Given this list of marker genes PCNA, ABCC3, RAP1A, ATF6, FRAT2, XPC, BTK, RHOT2, CXCR4, ERBIN, SRF, TMEM147, OSBP, SMARCD2, UQCRHL, GUSB (glucuronidase beta), ATP5MC3, KCNE5, TESK2, MGST2, SLC25A45, TIA1, TRIM11, HCFC1, C6orf136 (chromosome 6 open reading frame 136), NFATC1, CS, EEF1B2, H2AX, XPR1, SSBP2, RPS3, RANBP10, PBK, ABCB8, MED22 (mediator complex subunit 22, NCBI Gene Id 90955), ASGR2, SPN, KIF13A, RPS8, LARGE1, CENPV, ELOVL5, BDH1, B3GNT8, HGSNAT, SEC61B, IL7, TRIM32, IRAG2, GNA12, CSRP2, DSTYK, KIAA0930, FBL, EEPD1, RGS10, CYP2C19, GAST, RPL6, SELENON, PCID2, ABCG2, TPRA1, MGAT2, TMEM131L, CENPT, CMYA5, ATP5IF1, RHBDD3, GON4L, ZFYVE21, FUOM, VDAC1, CHMP1A, DGAT1, FAM162A, CREBRF, ABCD1, FAM53A, ANKRD54, PLD1, PIK3C2A, UCP2, RPL35 (ribosomal protein L35), CX3CR1, PPP3CA, OSBPL2, RNF149, HCFC1R1 (NCBI Gene Id 54985), CAVIN1, ALDOA, KCNK13, SLF1 (SMC5-SMC6 complex localization factor 1), FKBP11, CACNA1F, LEPROT, TMEM50B, MRAS, GPX4, KLHL9, ATRAID, NEPRO, GPR137B, PTPRS, GLIPR1, GUCA1A, GMPR, ACAT1, MDM1, IL6ST, PRELID1, SPC25, UGGT1, ARAF, ATP5F1B, ELP3, EHHADH, NDUFS5, NUDT4, ADAM11, NABP2, SIK1, TOMM20, PROM1, UHMK1, D2HGDH, ZNF280D, TGFBR1, TFCP2, AP5M1, AGL, GNPDA1, HAUS4, NANS, MRC1, ATP5F1A, TFEB, SENP3, PARD6A, G6PC1, ATP6V0D1 (NCBI Gene Id 9114), COA6, NFAM1, TFEC, MMP19, LRRIQ4, SWSAP1, TTYH2, CROT, BCL2L13, BCL2L11, F8A1, VPS35, MBNL3, S100A1, NEU1, STARD4, ATG12, CTSA, XPA (NCBI Gene Id 7507), FAM81A, CEP19, TALDO1, HPRT1, RXRB, ZNF318, CD300LD, NDUFA2 (NADH:ubiquinone oxidoreductase subunit A2), ENC1, TXN2, CD48, CCNB2, CDK1, IFI30, ATG2B, KIF1C, HAUS8, MRPL42, TBL2, HMGCL, KMT2E, SLC50A1, TEC, PLXNB2, CKAP2, BPHL, CMIP, GIGYF1, RBM5, WNT5A, SLC26A6, KIAA1143, HPF1, PHPT1 (phosphohistidine phosphatase 1), TRIP11, ADAM15, CCNI, RPL13, here is a description of the gene set: species: Homo sapiens mouse primary BMDCs were stimulated with tlr ligands and gene expression changes were profiled on Affymetrix arrays from publication Amit I, Garber M, Chevrier N, Leite AP, Donner Y, Eisenhaure T, Guttman M, Grenier JK, Li W, Zuk O, Schubert LA, Birditt B, Shay T, Goren A, Zhang X, Smith Z, Deering R, McDonald RC, Cabili M, Bernstein BE, Rinn JL, Meissner A, Root DE, Hacohen N, Regev A (PMID 19729616) Genes up-regulated in comparison of control dendritic cells (DC) at 12 h versus those stimulated with LPS (TLR4 agonist) at 12 h. Human Gene Set: GSE17721_CTRL_VS_LPS_12H_BMDC_UP